Given this list of marker genes Epb42, Rhd, Slc4a1, Rhag, Aqp1, Gypa, Ank1, here is a description of the gene set: A complex composed of ANK1, RHCE, RHAG, SLC4A1, EPB42, GYPA, GYPB and AQP1, that functions in the stability and shape of the erythrocyte membrane in human. Mouse Gene Set: GOCC_ANKYRIN_1_COMPLEX species: Mus musculus